The following is a description of a gene set: species: Homo sapiens from publication Kang SG, Park J, Cho JY, Ulrich B, Kim CH (PMID 20664575) Human Gene Set: GSE20500_CTRL_VS_RARA_ANTAGONIST_TREATED_CD4_TCELL_DN Genes down-regulated in CD4 T cells: control versus Ro 41-5253. This is to determine the T cell genes regulated by retinoic acid., and this is the list of marker genes: RPL18, E4F1, CMAHP, ATP5MC3, TSC1, BCAT2, SSX2IP, BLVRA, FOXRED2, ZNF135, TESK2, ZBTB14, VPS41, NELFCD, LSM4, PAPOLG, POLR2G, ZNF184, PTER, NDUFB8, ORC5, YLPM1, PEX1, POLR3K, RPS6KA1, KNOP1, SYNE1, CAPG, ARFIP1, VOPP1, PDSS2, GMNN, MRPL4, ETV5 (ETS variant transcription factor 5), GTF2H4, HPS4, BORA, DDX11 (NCBI Gene Id 93260), TARP, KAT7, PIP4K2C, TXNL4A, DDX28, FAM86C1P, NFKBIE (NCBI Gene Id 4794), POP1, MDM1, ZNF263, FUCA1, ALDH18A1, DIXDC1, POR (NCBI Gene Id 96440), RNASEH2A, ALDH5A1, ZBTB44, KDM6A (NCBI Gene Id 7403), PPP5C, EHMT2, IMP4, BCS1L, NBL1, XPO1 (exportin 1), NAT10, PSMB9, POLR2B, PRRG4, LIMK2, IDH1, PREB, PDS5B, DDX41, FAM13B, SCCPDH, BLCAP, ACTR5, SNAPC4, CENPM, MTNAP1, KDM3B, PLCG1, NSUN5P2, MRPL20 (mitochondrial ribosomal protein L20, NCBI Gene Id 64994), FEN1, SNHG17, TMEM62, GIMAP6, CTNNBIP1, RBPJ, LSM1, BUB1B, ATAD2B, PSMD9, RNF146, PLSCR1, CDK11A, PTPRA, SORT1, MRTFB, TRIM26, CXCR4, SUPV3L1, AHSA1, COLGALT1, CD244, NECAP1, FMO6P, DSCC1, POMZP3, ATIC, SHMT1, BAD, NGRN, PRR14, GINS2, ARHGEF40, TRAF4, TUBG1, CLSTN1, REXO2, TOR1A, BIRC5, PPP1CC (NCBI Gene Id 5501), UNC119B, TP53, PRC1, TUBA4A, CLOCK, TMA7 (NCBI Gene Id 51372), SNRNP25, RRP1B, GIMAP5, TNFAIP1, TMEM187, LGALS9 (NCBI Gene Id 90793), TMEM70, RLIG1, GABRA3, LARP1 (La ribonucleoprotein 1, translational regulator), RPA1, KIF17, SHPK, GOLGA5, TCFL5, PLK1, ZGPAT, GSTT4 (NCBI Gene Id 25774), MARCHF8, ECHDC2, MTIF2 (NCBI Gene Id 4528), FRAT1, UBB, NTAQ1, EVI2B, RABEPK, JADE1, COX7A2, RFXAP, ZNF443, SLC35A1, MAST2, ZNF280D, NDUFC2, ING4 (NCBI Gene Id 51147, inhibitor of growth family member 4), MPI, SOS1, UQCRFS1, GATD3, FLAD1, ELAVL1, CDC40 (cell division cycle 40), ECM2, NHEJ1, TRMT112, HPS6 (HPS6 biogenesis of lysosomal organelles complex 2 subunit 3), RUVBL1 (RuvB like AAA ATPase 1), CAV1, TRAPPC2L, THEM6, CAPN5, ZNF45, ZNF665, MRPS12, SMG8, RANBP1, MTERF1, HARS2, RHOA, ZNF551, MIEF1 (mitochondrial elongation factor 1), TRMT61B, JAG2, SSR1, VAMP8, GLOD4, RNF7, OSM, MPHOSPH10, SLC9A6